The following is a description of a gene set: Proteins classified as transcription factors constitute a disproportionate number of SUMOylation targets. In most cases SUMOylation inhibits transcriptional activation, however in some cases such as TP53 (p53) SUMOylation can enhance activation. Inhibition of transcription by SUMOylation may be due to interference with DNA binding, re-localization to inactive nuclear bodies, or recruitment of repressive cofactors such as histone deacetylases. part of: SUMO E3 ligases SUMOylate target proteins studied in species Homo sapiens Reactome Pathway: SUMOylation of transcription factors, and this is the list of marker genes: SUMO2, TFAP2C, MTA1, TP53BP1, CDKN2A, PIAS4, PIAS1, MITF, TFAP2A, TP53, FOXL2, SUMO3, PIAS3, PIAS2, SUMO1, MDM2, SP3, TFAP2B, HIC1, UBE2I